Given this list of marker genes MYO3A, MYO6, MYH1, MYH10, MYO10, MYH6, MYO5C, MYO9B, MYH7, MYH3, MYO5A, MYH15, MYH8, MYL6, MYO9A, MYH11, MYO19, MYO7B, MYO1H, MYH13, MYO7A, TNNT2, MYO1C, MYO1B, MYO15A, MYO1E, MYO3B, MYO1A, MYO1F, MYH4 (myosin heavy chain 4), MYH2, MYH7B, MYH14, MYO1D, MYH9, MYO1G, MYO5B, ACTC1, here is a description of the gene set: A motor activity that generates movement along a microfilament, driven by ATP hydrolysis. Human Gene Set: GOMF_MICROFILAMENT_MOTOR_ACTIVITY species: Homo sapiens